The following is a description of a gene set: Neighborhood of PRKAR1A protein kinase, cAMP-dependent, regulatory, type I, alpha (tissue specific extinguisher 1) in the MORF expression compendium Neighborhood of PRKAR1A Human Gene Set: MORF_PRKAR1A species: Homo sapiens, and this is the list of marker genes: PRPSAP1, RAN, LAMP2, PPP1R7, TIAL1, PGK1, CLEC18C, HADHB, SDHA, GMFB, CAPZA1, NDUFA1, CALM2, FBXW11, CLTA, RAB1A, MORF4L2, TMED2, LYPLA1, KDELR1, UGP2 (NCBI Gene Id 7360), PSMA4, GANAB, MTDH, RAC1, HSBP1, MBD4, COX7A2L, AHCYL1, SP3, RXRA, UBE2A, SDHC, SUMO1 (NCBI Gene Id 7341), PSMB4, IST1, CANX, TADA3, ARF3, RTCB, PSMB6, DRG1, COX7C, CYC1, MYL11, ENSA, FAM120A, JTB, CNIH1, MARCHF7, DCTN2, ATOX1, WBP2, AP2M1, CLN3, RAB5B, DYNLL1, TMEM59, DAP3, NDUFA2, XPC, PIGC, ATP6V0E1, YWHAZ, GORASP2, COX8A, SPCS2, SETD3, CAPZB, MDH1, METAP1 (methionyl aminopeptidase 1), MTA1, SMARCD2, SARS1, VGLL4, SRP9 (NCBI Gene Id 6726), GPAA1, COX6A1, PPP1CA, SEPHS2, ABR, NSF (N-ethylmaleimide sensitive factor, vesicle fusing ATPase), TOR1A (torsin family 1 member A), RBCK1, KARS1, UQCRB, PHF3, EFCAB14, ARCN1 (NCBI Gene Id 372), NCBP2, DYNC1I2, EIF4E2, RAB6A, EEF1D (NCBI Gene Id 87167), BCAP31, COG4, PDCD6, COX6C, NEDD8, RPN2, UBA1, GATD3, ATP6AP1, PRKAR1A, PSMB2, SNRPE, ARPC5, DNPEP, BANF1, SEPTIN2, COX4I1, KXD1, PPP1R11, ATP6V1H, COPS5, RAD23B, AP3D1, PSMD7, ATP5MF, YWHAB, CTDNEP1, SLC35A1, SUMO2, SEM1, SOD1, BZW1, PPP2R1A, STARD7, GLB1, COX5B, TMBIM6, ATXN2, ARF5, TRAPPC3, PUF60, ARFGEF1, CFDP1, RAD21, SSR2, PUM2, ZNF638, EBAG9, HSPA8